Given this list of marker genes APOE, TBX6, B2M, FOS, C1QB, PTBP2, RHOG, CTSH, HEXB, GFAP, AXL, AMH, TGFBR3, LMNB1 (lamin B1), CD24, UBE2H, LGALS3, PTPRO, MYH8, AGT, NR4A1, TYMS, MNAT1, SLC11A1, ACADVL, OR2C1, BDNF, C1QC (complement C1q C chain, NCBI Gene Id 90369), HNRNPH3 (NCBI Gene Id 3189), C4B, PGLYRP1, SPP1, TBC1D1, GNB2, SNTA1, HOXD12, C1QA, WDFY3, RPSA, CTSZ, SIPA1L2, HSPA8, CTSS (cathepsin S), F2, IARS1, HLA-DQB1, CAPN2, IGHM, CCL21, LGALS3BP, GCK, SELPLG, MPEG1, EPS15, NFYA, THBS2, EPRS1, TRIM5 (NCBI Gene Id 85363), IRF7, DNAJB2, PIGF, IFI27, IFIT1B, NOS3, CDK4, CST7, SEZ6, BCL2A1, ITGB5, APC, HMOX1, EIF2B5, CD68, SLC7A3, IRGM, HOXA4, NOTCH1, IMPA1, GNG11, TRAPPC5, EFS, CTSD, here is a description of the gene set: Upregulated in the cerebellum of aged adult mice (30-month) vs young adult (5-month) from publication Lee CK, Weindruch R, Prolla TA (PMID 10888876) studied in species Mus musculus Human Gene Set: LEE_AGING_CEREBELLUM_UP Ageing of the brain leads to impairments in cognitive and motor skills, and is the major risk factor for several common neurological disorders such as Alzheimer disease (AD) and Parkinson disease (PD). Recent studies suggest that normal brain ageing is associated with subtle morphological and functional alterations in specific neuronal circuits, as opposed to large-scale neuronal loss. In fact, ageing of the central nervous system in diverse mammalian species shares many features, such as atrophy of pyramidal neurons, synaptic atrophy, decrease of striatal dopamine receptors, accumulation of fluorescent pigments, cytoskeletal abnormalities, and reactive astrocytes and microglia. To provide the first global analysis of brain ageing at the molecular level, we used oligonucleotide arrays representing genes to determine the gene-expression profile of the ageing neocortex and cerebellum in mice. Ageing resulted in a gene-expression profile indicative of an inflammatory response, oxidative stress and reduced neurotrophic support in both brain regions. At the transcriptional level, brain ageing in mice displays parallels with human neurodegenerative disorders. Caloric restriction, which retards the ageing process in mammals, selectively attenuated the age-associated induction of genes encoding inflammatory and stress responses.